The following is a description of a gene set: from publication Gavin MA, Rasmussen JP, Fontenot JD, Vasta V, Manganiello VC, Beavo JA, Rudensky AY (PMID 17220874) Mouse Gene Set: GAVIN_PDE3B_TARGETS Regulatory CD4+ T cells (Tr cells), the development of which is critically dependent on X-linked transcription factor Foxp3 (forkhead box P3), prevent self-destructive immune responses. Despite its important role, molecular and functional features conferred by Foxp3 to Tr precursor cells remain unknown. It has been suggested that Foxp3 expression is required for both survival of Tr precursors as well as their inability to produce interleukin (IL)-2 and independently proliferate after T-cell-receptor engagement, raising the possibility that such 'anergy' and Tr suppressive capacity are intimately linked. Here we show, by dissociating Foxp3-dependent features from those induced by the signals preceding and promoting its expression in mice, that the latter signals include several functional and transcriptional hallmarks of Tr cells. Although its function is required for Tr cell suppressor activity, Foxp3 to a large extent amplifies and fixes pre-established molecular features of Tr cells, including anergy and dependence on paracrine IL-2. Furthermore, Foxp3 solidifies Tr cell lineage stability through modification of cell surface and signalling molecules, resulting in adaptation to the signals required to induce and maintain Tr cells. This adaptation includes Foxp3-dependent repression of cyclic nucleotide phosphodiesterase 3B, affecting genes responsible for Tr cell homeostasis. Genes changed in peripheral regulatory T lymphocytes that depend on PDE3B. species: Mus musculus, and this is the list of marker genes: Tfpi, Syt11, Sypl1, Nt5e, Il18, Ncf4, Gzmb, Lamc1, Tgfb1, Ebi3, Fgl2, Ncf1, Cybb, Sytl1, Ctla4, Tnfsf10, Il2ra, Hmox2, F13a1, Entpd1, Il10, Sytl2